Given this list of marker genes Kif1b, Raly, Syngr1, Calm3, Bpnt2, Map2, Tspan5, Syt6, Adar, Bag6, Ndst1, Uhmk1 (NCBI Gene Id 98572), Fam149b, Pptc7, Usp2, Chrm1, Chd8, Psap, Cry2, Kcnb1, Arnt2, Actr2, Cdh2, Rcc2, Arhgef2, Gria2, St6galnac6, Gad2, Rassf2, Mxd4, Prkcb, Adora2a, Mid1ip1, Ssr3, Aff4, Grin1, Camk2a, Acp1, Ids, Clcn4, Kcnh1, Dnajb5, Nfe2l1, Kif5a, Adcyap1r1, Arf3, Gnao1, Myh10, Hcn2, here is a description of the gene set: Mouse Gene Set: MCCLUNG_DELTA_FOSB_TARGETS_8WK DeltaFosB (a truncated form of FosB) and CREB (cAMP response element binding protein) are transcription factors induced in the brain's reward pathways after chronic exposure to drugs of abuse. However, their mechanisms of action and the genes they regulate remain unclear. Using microarray analysis in the nucleus accumbens of inducible transgenic mice, we found that CREB and a dominant-negative CREB have opposite effects on gene expression, as do prolonged expression of DeltaFosB and the activator protein-1 (AP-1) antagonist DeltacJun. However, unlike CREB, short-term and prolonged DeltaFosB induction had opposing effects on gene expression. Gene expression induced by short-term DeltaFosB and by CREB was strikingly similar, and both reduced the rewarding effects of cocaine, whereas prolonged DeltaFosB expression increased drug reward. Gene expression after a short cocaine treatment was more dependent on CREB, whereas gene expression after a longer cocaine treatment became increasingly DeltaFosB dependent. These findings help define the molecular functions of CREB and DeltaFosB and identify clusters of genes that contribute to cocaine addiction. from publication McClung CA, Nestler EJ (PMID 14566342) Genes up-regulated in the nucleus accumbens (a major reward center in brain) 8 weeks after induction of deltaFosB, a FOSB splice variant. studied in species Mus musculus